Given this list of marker genes CLN3, CAV2, CAV1, IQGAP1, FLOT1, PACSIN2, MIR138-1, ILK, COLEC12, ABCA7, COL6A1, EMP2, FA2H, CAV3, here is a description of the gene set: Human Gene Set: GOBP_PLASMA_MEMBRANE_RAFT_ORGANIZATION species: Homo sapiens A process that is carried out at the cellular level which results in the assembly, arrangement of constituent parts, or disassembly of plasma membrane rafts.